Given this list of marker genes DGUOK, UCKL1, UCK2, TK2, CMPK1, ADK, TK1, UCK1, NMRK1, DCK, NMRK2, here is a description of the gene set: Human Gene Set: GOMF_NUCLEOSIDE_KINASE_ACTIVITY Catalysis of the reaction: ATP + nucleoside = ADP + nucleoside monophosphate. species: Homo sapiens